The following is a description of a gene set: Human Gene Set: MIR647 Genes predicted to be targets of miRBase v22 microRNA hsa-miR-647 in miRDB v6.0 with MirTarget v4 prediction scores > 80 (high confidence targets). species: Homo sapiens from publication Chen Y, Wang X (PMID 31504780), and this is the list of marker genes: SRF, PLEKHS1, FAM149B1, TUBB6, GABRB2, NFATC2, PCGF6, SLC7A1, LCP1, CCDC28A, MYBL1, KPNA1, TBC1D16, SCN8A, INSYN2A, CELF4, ZBTB44, GSDMB, MDM1 (NCBI Gene Id 56890), CADM3, KIAA0930, C1orf122, ARK2C, PML, SYVN1, TMEM143, TRAK2, PLD1, EFEMP1, SLC44A1, ARID1A, PLCL2, ARNT, ZDHHC14, SS18, AFF3, RSPRY1, ZC3H7B, BARHL2, ALCAM, NIPBL, ASPH, RNF208, KIF26A, SMCO1, GRIA2, CEP350, TMEM91, SLC9A6, ENSG00000215022, HNRNPF, EAF1, SMURF1, DESI1, PPP1R14D, ICOS, ZFAND3, KIAA1143, ALOXE3, TRABD2B, EXOC5, PRRX1, UBE2Q2, ABCC9, IFIT2, THOC5, S1PR5, DCX, ZBTB41, ELOC, C9orf153, ATP8A2, SEC14L1, CPEB2, KCNB1, ZBTB37, C1orf127, UPF3B, FBN2, WASF2, CDIP1, AP5M1, CCDC6